The following is a description of a gene set: from publication Ng SY, Yoshida T, Zhang J, Georgopoulos K (PMID 19345118) Human Gene Set: GSE15330_MEGAKARYOCYTE_ERYTHROID_PROGENITOR_VS_PRO_BCELL_DN Regulation of lineage potential and transcriptional priming by Ikaros. New insight is provided into a bivalent regulation of lineage priming in the HSC and its lympho-myeloid restricted progeny the LMPP by the lymphoid lineage-determining factor Ikaros Whereas Ikaros is responsible for the activation of a cascade of lymphoid expression programs and for the establishment of lymphoid potential from the HSC to the LMPP it is also responsible for the repression of stem cell and erythroid genetic programs that are incompatible with further lineage restrictions emanating from the LMPP species: Homo sapiens Genes down-regulated in megakaryo-erythrocyte progenitors versus pro-B lymphocytes., and this is the list of marker genes: GRK5, IGSF9, IFT22, GSS, HAUS5, CHST2, SAP18, MBNL3, ZC3H12C, HMGB2, SRSF1, NUCB1, PTDSS2, HAGH, PRKCI, PCNA, MYD88, RITA1, RBBP7, IFTAP (NCBI Gene Id 119710), PHACTR2, ZNF451, PARN, CHAC2, NDUFA13, SPTSSA, BLZF1, SNRPB2 (NCBI Gene Id 6629), REEP3, AMPD2, RCC1L, PRKCSH, PAFAH1B2, BLMH, GALK2, RYK, NOL12, MRPS5, PRMT2, HMGXB4, GCDH, SMIM11, LYPLA1, C1D (C1D nuclear receptor corepressor), NUDT13, DIPK1B, SDHA, CMPK1, GATM, SH3BP2, RPGRIP1, SEPHS2, PTGER2, PFDN1, CRB1, DYNLT1, HDAC2, ATOX1, SENP3, DNAJC18, CD80, HCCS, TEX9, CCDC107, PSMB9, C8orf82, BLOC1S6, ADRM1, SMIM30, PDIA6, C1orf174, SELENOF, PSMB1, FANCG, IQGAP3, ZCCHC3, DEDD, EIF4A3, KCTD1, PSPC1, SERPINE1, NEIL3, STC2, MDH2, TOMM70, UBE4B, INTS8, PTGER4, FBH1, RAB8B, CUTC, IPO9, ZNF426, CSTF1, VPS25, MED21, EGLN3, FMC1, POLD1, CCT5 (NCBI Gene Id 22948), SOD2, TM2D3, FBXO45 (F-box protein 45), PLAAT1, UPF3B (UPF3B regulator of nonsense mediated mRNA decay), EXTL3, TYW5, HIRA, KCNK10, AP3S1, SSR1 (signal sequence receptor subunit 1), HMGB1, PWP2, PYCR1, WASHC3, HSBP1, POLDIP2, ATP10A, PYCR2, FKBP1A, PTP4A3, UBAP2, SNX10, NME7, GPR180, YWHAQ, NCAPH2, CDKN2C, GSTZ1, LMNB1, GJA1, RXYLT1 (ribitol xylosyltransferase 1), CAAP1, CPPED1, DALRD3, MMUT, GTF2F2, TOMM6, PIGS, RSRC1, TPD52L2, DNAJC9, MTIF2, POLE3, PLOD3, ARL14EP, POLE2, SVOP, SLX9, NIP7, TMED4 (NCBI Gene Id 222068), NDUFS8, APTX, GJC1, ABCG2, ANAPC1, ZNF235 (zinc finger protein 235), COMMD9 (COMM domain containing 9), PIGU, ZDHHC3, IRS4, MTX1, PPP5C, VIM, CHPT1, TIMELESS, RCC2, NCF4, TXNDC5, SRSF3, JMJD8, ALDH9A1, TIMM17B, GGA2, NUFIP1, ENY2, TAF11, ERMP1, ATP5PB, LAMTOR3, TMEM184C, TNFSF11 (TNF superfamily member 11), KATNB1, STMP1, PHLDB1, PTPRCAP, GRHPR, UBE3C, SCAF11, ARPC5L, HDDC2, NABP2, RPL24, EPRS1, MRM2, HNRNPC, IL15RA, RIF1, NDUFV2